Given this list of marker genes LZTS1, MINPP1, DCC (DCC netrin 1 receptor), RHBDF2, STK11, MSR1, PDE11A, ASCC1, STAT1, MYH11, TGFBR2, CDKN2A, DLEC1, PDGFRA, PRKAR1A, COL14A1, WWOX, FH, BLM, CTHRC1, FOXE1, RAD21, CHEK2, HABP2, APC, SDHB, KIT (KIT proto-oncogene, receptor tyrosine kinase), CTNNB1, TP53, COL4A6, COL4A5, SDHA, AAGAB, MDM2, RNF6, SDHC, here is a description of the gene set: species: Homo sapiens A tumor (abnormal growth of tissue) of the head and neck region with origin in the lip, oral cavity, nasal cavity, paranasal sinuses, pharynx, or larynx. Neoplasm of head and neck Human Gene Set: HP_NEOPLASM_OF_HEAD_AND_NECK